The following is a description of a gene set: Any process that results in a change in state or activity of a cell or an organism (in terms of movement, secretion, enzyme production, gene expression, etc.) as a result of an ammonium stimulus. Human Gene Set: GOBP_RESPONSE_TO_AMMONIUM_ION species: Homo sapiens, and this is the list of marker genes: GRIA1, CPS1, KCNC2, ASS1, ADSS2 (NCBI Gene Id 159), SLC1A1